The following is a description of a gene set: studied in species Mus musculus The directed movement of substances from endosomes to lysosomes by a pathway in which molecules are sorted into multivesicular bodies, which then fuse with the lysosome. Mouse Gene Set: GOBP_ENDOSOME_TO_LYSOSOME_TRANSPORT_VIA_MULTIVESICULAR_BODY_SORTING_PATHWAY, and this is the list of marker genes: Chmp1a, Chmp7, Rufy4, Chmp4c, Chmp5, Lyst, Chmp3, Chmp1b2, Chmp1b, Ubxn6, Mvb12a, Vps4b, Chmp2b, Chmp2a, Chmp6, Vps4a, Vcp, Chmp4b